The following is a description of a gene set: Mouse Gene Set: MIR_12182_3P from publication Chen Y, Wang X (PMID 31504780) species: Mus musculus Genes predicted to be targets of miRBase v22 microRNA mmu_miR_12182_3p in miRDB v6.0 with MirTarget v4 prediction scores > 80 (high confidence targets)., and this is the list of marker genes: Cdkn2c, Hdac8, Atp6ap2, Gucy1a2, Crtam, Tssk4, Lmx1a, Srsf12, Ccdc167, Zfp148, Utp18, Mex3c, Klhdc1, Atp2b1, Plxna3, Il3, Tor1aip1, Syf2 (SYF2 homolog, RNA splicing factor (S. cerevisiae)), Kifc2, Fabp12, Fstl5, Fancf, Ube2z, Sema3a, Flacc1, Cpeb3, Usp38, Chd9, Sec24d, Eif3a, Bcor, Pdzd8, Slc25a13, Lrrtm2, Slu7, Egf, Cops7b, Sema5a, Sntg2, Palld, Prickle1, Kmt2a, Irx5, Fundc1, Lipt2, Kdm7a, Smagp, Adgrl2, Tmem254, Bag5, Ube2k, Trpc1, Mapk8, Trrap, Ptpn20 (protein tyrosine phosphatase, non-receptor type 20), Atg3, Rap1a, Frmd7, Nfat5, Hook3, Ss18l1 (SS18, nBAF chromatin remodeling complex subunit like 1), Pbrm1, Med14, Gm5148, Vps50, Vsnl1, Plcxd3, Tmem117, Snrnp48 (NCBI Gene Id 68788), 2510039O18Rik, Zeb2 (zinc finger E-box binding homeobox 2), Ino80d, App, Usp32, Tshz3, Kifbp